The following is a description of a gene set: species: Mus musculus Mouse Gene Set: GOBP_PROTEIN_TO_MEMBRANE_DOCKING The initial attachment of a protein to a target membrane, mediated by a proteins protruding from the target membrane. Docking requires only that the proteins come close enough to interact and adhere., and this is the list of marker genes: Snx3, Pex26, Pex16, Rab7, Stxbp3